The following is a description of a gene set: Human Gene Set: GOBP_REGULATION_OF_CLATHRIN_DEPENDENT_ENDOCYTOSIS studied in species Homo sapiens Any process that modulates the frequency, rate or extent of clathrin-mediated endocytosis., and this is the list of marker genes: TNK2, DNAJC6, NEU3, UNC119, DAB2, BMP2K, PIK3CB, PROM2, USH1G, HIP1R, UBQLN2, SMAP1, SNAP91, SH3GL3, AAK1, DGKD, CCDC32 (NCBI Gene Id 90416), WASL